Given this list of marker genes CSF1, NR4A3, TYROBP, KIT (KIT proto-oncogene, receptor tyrosine kinase), LAPTM4A, SLC18A2 (NCBI Gene Id 6571), ZNF331, SDCBP, TPSB2, STX3, LMO4, LTC4S, RAB27B (RAB27B, member RAS oncogene family), RGS13, EMP3, DNAJB1, FCER1G, CTSG, CD83, NFKBIA, CD69, PLIN2 (NCBI Gene Id 123), CKLF, MAOB, ANKRD28, FCER1A, CREM, NFKBIZ, ADRB2, CD44, FTH1, HPGD, RAC2, VWA5A, ALOX5AP, EGR3, MS4A2, IL1RL1, SAMSN1, SRGN, RHEX, RGS1, SOCS1 (NCBI Gene Id 8651), TPSAB1, DUSP2, BIRC3, RGS2, ARHGAP18, HPGDS, PTGS2, AREG, LIF, IER2, CCL2, DDIT4, CAPG, ACSL4, GPR65, NR4A2, CAVIN2, HSPA1B, GATA2, TNFAIP3, PPP1R15A, ELF1 (E74 like ETS transcription factor 1), CD37, SELENOK, SLC45A3, DUSP6, CPA3, HDC, CCL4, PLAUR, SGK1, here is a description of the gene set: studied in species Homo sapiens Human Gene Set: DURANTE_ADULT_OLFACTORY_NEUROEPITHELIUM_MAST_CELLS from publication Durante MA, Kurtenbach S, Sargi ZB, Harbour JW, Choi R, Kurtenbach S, Goss GM, Matsunami H, Goldstein BJ (PMID 32066986)